Given this list of marker genes FIZ1, ZHX1, SAMD1, AIG1, MICALL1, MORF4L2-AS1, LPXN, VEZF1, METTL27, ABHD17A, XPO1, IMPDH1, ZKSCAN2, CTBP2, SHOX2, PKP2, CTDP1 (NCBI Gene Id 9150), GUK1, GMPR2, PCBP1-AS1, BRPF3, ZDHHC8BP, RHBDD2, FBXO24 (NCBI Gene Id 94779), ZMIZ2, PTPN12, IST1, POLR2J2-UPK3BL1, ASCC1, FXYD5, CMIP, RBM26, TSPOAP1, ZNF524, PTPN18, VEGFA, EOLA2, C6orf89, ELP1, HLA-DMA, DIS3, USP21, MAP3K8, NFATC2, RREB1, ZZZ3 (zinc finger ZZ-type containing 3), VANGL2, CDK13, PUSL1, TRABD, GRIN3B, NCAPH2, SAP25, ENSG00000246090, POLR2J3, CHD4, NOTUM, ASXL1 (NCBI Gene Id 23393), HSDL2, P3H3 (NCBI Gene Id 10536), ZNF787, ENSG00000221040, RHBDF1, TPR, RFX7, PPP1R15B, UBE2E3-DT, ZFAND2B, CERS4, OARD1, E2F3, STX16, BHLHE40, HIVEP1, ZNF217, HDAC7, GPR199P, LINC02965, FAM193A, MXD1 (MAX dimerization protein 1), LDAF1, RCOR1, INPP5D, HSPB9, CYFIP1, HOXB-AS1, LINC01391, USP34, EIF5A, RIMKLB, BBX, ZBTB18, MILR1, CAPN1-AS1, ID1, NFKBIA, KMT2D, ENSG00000277182, SFR1, B4GAT1-DT (B4GAT1 divergent transcript), NDUFB2, FLT3LG, USF2, FKRP, CYB5R1, API5, GLUD1, PIPOX, GSTO1, BMP2K-DT, ZNF442, RBCK1, HEATR6-DT, CLDN4, RNU5A-1, UNKL, TUBB2A, GABARAP, ERP29, POC1B, JUN-DT, UBE2I, YWHAZ, GFOD1-AS1, PCGF2, RPGR, MIR4766, TOP1MT, CRK, ENSG00000260132, GATAD1 (NCBI Gene Id 79636), OBSL1, FOXP1, AMOTL1, CAPZB, FAAP20 (NCBI Gene Id 199990), ZNF623, RASA1, GAB1, TPT1, PAN3-AS1, PPM1D, LINC01623, RNY4, BMI1, EPHB4, KCNJ4, NOVA2, FLII, ATP8A1-DT, HJV, STK11IP, C8orf58, ATXN1L, TRMT12, ZNF559-ZNF177, ARFIP1, PSCA, RPL23A, APBA2, UQCR11, MYCBP2-AS1, BRAF, TMEM256, TMEM256-PLSCR3, NBN, SPRED2, SMG7, SNHG26, NRN1L, TM9SF4, AHDC1, ATXN2L, ZFP91, SMIM10L2A, FBXL19, VCF1, RGS4, HOXB3, GPR180 (NCBI Gene Id 160897), INPPL1, TSPAN31, UTP4, RNF14, HMG20B, CDC25C, GIPR, TSPOAP1-AS1, ZNF664 (zinc finger protein 664), C11orf71, ANKRD13C-DT, ABITRAM, CDK12, ARAP1, USP32, DNAH17-AS1, RNVU1-28, MIR9-1HG, HSP90AB1, YWHABP2, ANAPC13, VPS37B, ZBTB22, MAN1C1, GLA, HMGN2, SH2D6, SPRY2, LAMA5, MAST1, ARHGEF7, MIR193BHG, CYTH1, SBK1, CXXC5, ANXA4, CEBPG, TUBA4A, MAML2, GET1, ZXDC, ATP6V1G2-DDX39B, NFIC, ADGRE5, DLGAP1-AS1, SYCP2, SLC39A7, SCYL1, PGAP6, EIF4G3, ECI2, ZFP36L1 (ZFP36 ring finger protein like 1), HYAL2, HCFC1, METRN, DCAF5, RIC1, HNRNPH3, KRI1, ZER1, ZNF579, GCC2-AS1, MATK (NCBI Gene Id 4145), CCND2-AS1, OLFM2, CNOT8, KLF3-AS1, KCNQ1OT1, ATP1B2, GDF11, LDHA, LINC02252, RGL1, CCDC77, UBE3D, UBAP2L, DBNDD1, SDCCAG8 (SHH signaling and ciliogenesis regulator SDCCAG8), ILRUN, F2RL3, TBXAS1, ASB7, SUPT3H, DVL3, FCHO1, PFN1, PLA2G12A, GFOD1, HMGB1 (high mobility group box 1), PSME4, SMIM29, SSC4D, MRPL36, SDCBP, ALAD, CHCT1, FAM21EP, ANKRD13B, SNORD42B, WDR26, PKNOX2, NIPA1, MIR4487, MTNAP1, CSNK1E, IL6ST, CLCN2, PPP2R1A, DENND1C, N4BP2L2, BCR, DCP1B, PAQR6, SAT2, ANKRD62, ANP32B, SHLD2, NR2F6, GPBP1, TNFAIP8L1, COX17, FTX, APH1A, EXOC3L4, PGM3, MIR3190, SCN1B, SYNCRIP (synaptotagmin binding cytoplasmic RNA interacting protein), BCL2L2, ZBTB14, H4C8, ZEB2, TPT1-AS1, DPP9, SPAG1, MAGEA1, HDAC6, BZW2 (basic leucine zipper and W2 domains 2), CCDC92 (coiled-coil domain containing 92), DNAH2, DTD1, KTN1-AS1, SCRT1, USP34-DT, MEIS3, ZBTB39, SBNO1-AS1, NEXN, MIR1538, PPP1R10, MARCHF2, GFI1B (growth factor independent 1B transcriptional repressor), DNAJC30, PKNOX2-DT, SLC12A9, PCBP2, RPS6KA4, TBC1D8B, CA11, TMEM70, TTC5, EFCAB5, TRIM46, MED13, BRD2, PIAS2, SDF4, MIR378D2HG, SMAD3, YES1, HNRNPLL, SNAI1, TRIB2, DAND5, SEMA4G, POLR1D, FSD1, ADH5, TMED3, RPUSD1, SMPD4BP, MEF2C-AS1, OPLAH, RFLNA, AUP1, EPHA2, TUG1, PNPLA7, RASSF5, STAR, PPP1CC, ATP6V1G2, ZNF410, ZBTB21, TRMT112, PIAS4, YWHAE, BAG2, CHRNA1, CADM1, UBR4, CEP131 (centrosomal protein 131), ENSG00000230226, TXN2, TSC22D1, MTBP, MACIR, CASTOR2 (NCBI Gene Id 730322), APC2, ENSA, PGGHG, PRAME, UCK1, SETD1B (NCBI Gene Id 23067), NAGLU, PLXNB1, TEAD2, PHF1, SLC18B1, PDE4A, LRCH4, GRPEL2-AS1, ADPGK, SUMO2, ABL2, DUSP16, ADD2, TONSL, DCLRE1A, ENSG00000246465, MAX, HDHD5, DSN1, MYO15B, TTC7A, JRK, PFKM, RELA, PPP4R1L, ATP5MC1, GSPT1, SPESP1, ATP8B3, CPT1C, INPP5J, LRRC58, ODR4, VRTN, ATP2B4, MIDN, MEX3B, PPP1R26, ACTR3, TET3 (tet methylcytosine dioxygenase 3), TXN, ABCA7, KLF4, MIR497HG, MFN1, MICU3, POLR2J2, CNTN3 (contactin 3), NOSIP, SNORD101, MCMBP, GRK6, EOLA2-DT, SLC2A1, GSTM4, SGCE, ZNF467, DENND4B, USP38-DT, FGFRL1, TRPS1, KCNJ8, KIF21A, UBR1, SYNGAP1, KDM6B, HNRNPF, SNORD3J, PLAGL1, TMEM35B, GART, RCAN3, AMPD2, AKT2, ENTPD6, TYW3, TPX2, RPS6KA3, FABP5P3, POLR2A, IER2, HHEX, MVB12A, RSF1, NAA50, U2AF2, TFB2M, CITED2, HLX, PRR34, SSNA1, SLC25A6, MIR548AW, CD99P1, SRRM1, HARBI1, CHD1, SCAMP2, ZEB1, ZNF592, SOX5, GBA1LP, SLC1A4, SATB2, LIMS1, INTS6-AS1, ZNF581, ITPR3, TPP1, DDIT3, TMEM116, MIR9-3HG, ZC3H7A, PIK3CA, C3orf38, GRHPR, IFIT1, GAS8, BCL2L2-PABPN1, PCF11 (PCF11 cleavage and polyadenylation factor subunit), ANAPC16, PRMT1, NUMA1, ZNF580, SUSD6, FKBPL, LINC02870, HNRNPA2B1, IDI1, MFSD5, IRF2BP1, KLF6, TM2D1, MRPL13, COIL, LINC01366, VAV1, ZDHHC3, TARBP2, PAXIP1-DT, LACTB2, ZFP62, LENG8, ZNF200, GSTM2, COPZ1, HNRNPH2, LINC02130, CUX1, CALM1, MATN1, CYLD, PITPNM3, SRRM2-AS1, RHBDL1, LIG4, PRR12 (NCBI Gene Id 57479), H3-3A, NME3, ZMIZ1-AS1 (NCBI Gene Id 283050), SATB1, NFKB1, AMD1, PRDM10-DT, POLK, ZNF628, CCDC28A-AS1, RBM10, TLE2, SINHCAF, TSPAN4, UNC13A, KRT8, MIR3613, RNF44, BPTF, BEST1, NUDT12, MATN1-AS1, SLC40A1, STK35, TNRC18, TFEB, FXYD7, AMN1, SYCN, TULP2, BCL9, EIF4E1B, LMNB2, AARS1, SLC16A6, MAPK11, CTSH, TLE5, CDCA4, NUDT18, RPS2P4, ATP8A1, FAM193B-DT, TACC3, KMT2C, INF2, CSNK2B, KLHDC4, GGPS1, EIF4A1, ANTKMT, LZTS2, AP1G1, NEO1, ZC3H4, SIK3, NFAT5, SP1, TNKS1BP1, CACNA2D2, RAB10, SCIN, DIAPH1, CDC26, BCL3, RPL36P10, ARL6IP6, JADE2, DNAJC7, TPTEP1, CYREN, ERFE, CLIC2, RETREG2, SSBP3, DNAJB13, EPC1, DDX19B, AAK1, POLN, STRN3, C4orf36 (NCBI Gene Id 132989, chromosome 4 open reading frame 36), SNORA48, LINC02028, PALM3, ARPC5, HOXB5, CILP, ZBTB12, AGPAT3, TFE3, ROCK2, KDM2B-DT, POLR3K, QKI (QKI, KH domain containing RNA binding), PAFAH1B3, INHA (inhibin subunit alpha), ARAF, ITGA5, ZNF227, EIF2D, AGAP1, MPP1, GTF2I, HTRA2, MIR6089, NKRF, RNF2, KLHL25, H2BC5, BCAR1, RUVBL2, HDHD5-AS1, DMXL1, CGRRF1, ASTN2, FCHSD1, CIRBP (cold inducible RNA binding protein), ARHGAP22, GAD1, HR, TENT4B, LEPR, TMEM259 (transmembrane protein 259), RPS7, ELF2, RAD17, RPTOR, MTCH2, RN7SKP175, ZNF280D, GTF3C2-AS2, COX20, NYAP1, WDR37, SRCIN1 (NCBI Gene Id 80725), RELT, DPP8, UBE2Z, DIXDC1, GLS, STXBP4, KDM3B (lysine demethylase 3B), HS3ST3B1, ZBED6, STAG3, SS18L1, PAXIP1, PAX6, CUL4B, MCCC2, TLK1, TAF9, MMACHC, NEDD8-MDP1, KIFC2, HEXIM2, MGAT4B, DPF1, FAM72A, TMC6, GHDC, PRELID3BP5, WSB2, MAP1A, MTF2, RBM3, HEXD, FARP2, SAE1, VIRMA, GPANK1, ZNF628-DT, MOB3C (MOB kinase activator 3C), CFAP298, PARK7, PURB, ARHGAP23, PPP1CA, LSR, ACTR8, SCML1, SQSTM1, VAT1, CDC42EP1, TRIM32, TMEM187, ZNF783, CAMTA2, SLX4, PANK3, MYL6, BRSK1, CDKL3, TIGD5, WEE1P2, PHACTR2, NATD1, ZKSCAN8, IRF2BP2, CDC16, MME, BCL2L1, ANP32A, FOXP1-DT, ZFP91-CNTF, PTPRS, CNTRL, WDR54, LRCH1, SNORA57, ATP7B, ZNF211, HSP90B1, AMPD3, INO80D-AS1, EOGT, RNVU1-15, EP300, UBTF, PIK3CA-DT, LINC01134, NUCB2, LINC03016, DNAAF10, HSDL2-AS1, RNU6-2, MORF4L2, GTF2IP1, ADSS1, TMED1, CNIH3, AHNAK2, RAE1, CLTC, MPG, CHD7, HSD3B7, WDTC1, PSMA7, RBM39, LAMTOR3, CHRNA7, CNOT4, EFHD2-AS1, DAXX, CASZ1, TGFBR3, DDX11L17, STX16-NPEPL1, TP53INP1, GNB2, BBC3, RASL10B, BRI3, GTF2IP4, CSKMT, MLST8, TAGLN2, ELFN1-AS1, CMTM3, PRRT1, DNAJA1 (NCBI Gene Id 4737), HMX3, XKR9, GRTP1, ZKSCAN5, HMGB1P50, TAF15, RFPL1S, MIR6835, R3HCC1, PPFIA3, SMPD4, TPTEP2, PRPF40A, SNHG25, EFHD2, HSF2, UBXN11, C1orf174, TNRC6A, FAM117B, SPART, IKZF4, PMS2P4 (PMS1 homolog 2, mismatch repair system component pseudogene 4), ST7L, RNVU1-27, SOX18, RPS6KB2, DYNC1LI2-DT, CNPPD1, KMT5B, LURAP1, EPC2, CAMSAP2, ACTR3B, AP2A1, MAGEC1, MIS12, VIRMA-DT, LRRFIP1P1, ZHX1-C8orf76, LTBP4 (latent transforming growth factor beta binding protein 4), CHIC1, PROSER2-AS1, AP3M1, TENT2, WDTC1-DT, JPH3 (NCBI Gene Id 57338), MTA2, KPNB1 (karyopherin subunit beta 1), MPHOSPH9, MTPAP, URAHP, SLCO4A1, SFMBT1, SLC20A1, HAUS8, ENSG00000229227, CCDC183, USP44, SUMO1, ANP32E, XIST, PTPN7, LINC01521, NME4, TRIM25 (NCBI Gene Id 7706), RTL6, SSR1, S100A1, ARAP3, ZNF653, SMG7-AS1 (SMG7 antisense RNA 1), CRYZ, GATA2, LAX1, SMARCA4, HEXIM2-AS1, MAGED2, ANKRD34A, NIBAN2, TTC17, HID1, LRRC4B, PHF23, IDH1, FAM193B, TOP3B, CPSF1, COL1A1, MUC4 (NCBI Gene Id 55804), GTF3C2, SATB2-AS1, CLPX, SLC12A2, ZSCAN31, ZNF710, SH2B3, LINC02916, PLEC, MDM2, FUNDC2, GAB3, TMEM198B, LINC03072, SMIM27, UBA7, NDE1, KAT6B, TSHZ1, AP4S1, OAF, ELAVL3, ATP1B3, PI4KB (phosphatidylinositol 4-kinase beta), LINC01732, HAUS3, BCL9L, DHRSX, EHD1, TAL1, DUSP7, RABGAP1, PHF12, ATP6V1A, PCNX4, RCOR3, SLC7A6, PIKFYVE (NCBI Gene Id 387568), RNF43, KCTD15, STMN1 (NCBI Gene Id 3925), ZBED1, F8, PLCG1-AS1, MUL1, HOXB9, FTL, TSC1, MAGEF1, SNORA56, GNL3L, ZC2HC1C, AKAP9 (NCBI Gene Id 10582), ZNF687, ABTB2, IGLON5, ZNF395 (NCBI Gene Id 55893), DYNC1LI2, IGF2R (insulin like growth factor 2 receptor), LMAN2L, PDGFA, DNALI1, ING1, SNRNP25, TMIE, CARS2, LDAH, TEX14, CREB3L1, MIR4472-2, TMCC2, MMP25-AS1, TGIF1, CGGBP1, LEMD1, MNS1, RARA, LIN28A, JUN, EIF3J, ADK, GPR107, TFDP1, WDR90, MEF2C, FGD6, LGI4, KLK10, CCDC106, NUP153-AS1, EIF4G1, SCARB1, HERC4, SMG1P3, INTS6, VPS11, PDE3B, SYT3, APEH, INHBE, MAP3K12, ZC3H3, TBX21, MAPKAPK3, AKIRIN1, DDX23, RPL7A, PRR5 (NCBI Gene Id 86335), NFIB, ZNF687-AS1, ELOA-AS1, MMP17, SSRP1, NDST1-AS1, NFE2L2, MANSC1 (NCBI Gene Id 54682), ZNF771, MAP1B, BUD23, RNU2-17P, SNX16, CEP164, VPS51, RCN1, VSTM5, USP22, JADE1, LNX2, C19orf38, DNAJB2, IMPA2, NDUFAF2, BRWD3 (bromodomain and WD repeat domain containing 3), LCORL, ZNF346, DNMT1, PCGF1, ELF4, TMEM129 (transmembrane protein 129, E3 ubiquitin ligase), ENSG00000267424, AFF1, KAT2A, ARRDC2 (NCBI Gene Id 27106), KMT2A, PRKD2, SH2B1, BRPF3-AS1, DMXL1-DT, EXOSC7, CCDC163, ITGAV, ATG13, PNRC1-DT, TEX9, WAC, KCNIP2, PDGFA-DT, MYO18B, S100A13, ASH1L, PEG10, RICTOR, RAP2C, ZHX3, RLN3, ARCN1, CD81-AS1, SHKBP1, MGME1, WIZ, SEPTIN2, TOB2P1, UBE2V1, STMN3, METAP1, TBC1D32, ATXN7L3, ESR2, MIR3181, PNISR (PNN interacting serine and arginine rich protein), PCYOX1L, GPR161, EZH2, MIR6821, PTPN4, MIS18A, YLPM1, CTCF-DT, TERC, MLLT6, ADNP, LINC01229, CHTF18, SEPTIN11 (NCBI Gene Id 55752), NSD1, JAG2, ADAM17, CD9, TNK2, ZNF436, FAM83E, C1orf74, DDX55 (DEAD-box helicase 55), ELOC, BCORL1, CDK13-DT, CTPS1, DCTN4, ATP11C, USP38, WDR83OS (NCBI Gene Id 51398), RPL41, HEY1, SRSF1, PNRC1, ABHD6, MIR4285, SHFL, QPCT (NCBI Gene Id 25797), LINC02920, E2F2, CHRNE, POLE3 (DNA polymerase epsilon 3, accessory subunit), SLC12A2-DT, BNIP1, ECI2-DT, RBFOX2 (RNA binding fox-1 homolog 2), TMEM245, UBE2E3, EPM2A, PICK1, LINC02332, ZKSCAN2-DT, UBE2Q1, TRPA1, NBR1, NFATC3, WASL-DT, ANKMY2, ARPC1B, C1RL, REM2, PDXK, B4GAT1, NES, C1orf43, INO80, FOXO4, CCND2, F12, POU2F1, CDK5RAP3, PROCA1, HMG20A, PLEKHA7, LRRC51, GGA2, KIAA0586, DHRS13, ARHGAP5, GYS1, EFCAB14, MBD5, CEP63, DGKZ, LEPROTL1, WAPL-DT, TRMT61A, TTC41P, POLR2L, PHF21A, RBM7, SKIL, CSF3R, EBP, PDP1, EIF4B, EEF1D, PSMD7, PIK3R1, ITPKB, BRD7, WRNIP1, C19orf73, RHOBTB3, MIR1208, CLCNKB, ARID4B, LINC01144, BLVRB, ZNF329, CDK5RAP2 (NCBI Gene Id 55755), GLI1, BTNL12P, HOXC9, DERL2, DENND1B, EIF3J-DT, NAA40, SEMA4C, C9orf43, KDM2B, SNORD104, MAP2K4P1, WDR43, PUM1, ZNF768, LNCPTCTS, FAM78B (family with sequence similarity 78 member B), SBNO1, TMTC4, SKIDA1, LINC00620, MCFD2, PURA, LDOC1, TMEM120B, VEGFB, MMP11 (matrix metallopeptidase 11), H3-3A-DT, MBOAT7, TRAF3, TASOR2, KDM2A, MRPL41, ENTPD3, SDC4, MBD6, GNAI2, ATXN2-AS, SLC8A2, TUBB, NHLRC2, TRMT61A-DT, CACNA1H, HOXB2, CLK4, SLC25A22, FOXJ2, LNC-LBCS, UBE3A, PLXNA3, GTF2IRD2B, TPP2, HOXB6, MAFA, ZNF644, TPGS1, RPRD2, RAB3IL1, STX6, MAGI1 (NCBI Gene Id 9223), MLLT10, GCAT (NCBI Gene Id 23464), NCOA2, STRN4, YWHAG, NEAT1, MIR4729, ZEB1-AS1, RGL2, DLG4, ZDHHC8, HNRNPUL1, SMARCA1, TCF4, CLDN6, ADD3, CAPZA1, TLK2, TMEM216, SRGAP2, ATP5F1A, PRDX4, CROCC (NCBI Gene Id 9696), ARHGAP5-AS1, NLK, GRIK5, KCNN1, COPS7A, MECP2, ATF6B, KDM5B, MZT2A, ACYP2, HDLBP, NFKB2, CRB2, ZNF436-AS1, DHX58, FXN, HMGN1, ANKRD11, DKKL1, KAT6A, SLC25A17, SEC13, TPSP2, CCDC66, S1PR2, PAFAH1B2, LMNA, DPY19L4, PSMB6, EPC1-AS2, XKR6, NOTCH3, CTC1, LMF2, DBP, RBM33-DT, MED13L, RND2, RAB7A, UBL3, ATXN7L2, CCL3-AS1, C11orf98, ACAP3, RCAN1, POLR2E, ZEB2-AS1, RNU6-268P, SAMD12, HDHD3, MIR4492, CRACR2B, MIR4466, VAV2 (vav guanine nucleotide exchange factor 2), SRSF10, LINC01635, HSPB8, SHBG, ADAR, TRIB1, MADD, ORC4, RNVU1-18, ZNF503-AS1 (NCBI Gene Id 253264), PNO1, CHCHD10, SPTBN4, G3BP2, NFYA (NCBI Gene Id 56008), TMEM39A, PATZ1, ATXN2, ACYP1, HSP90AA1, POLR2J, LMO4, ENSG00000187186, BLVRA, MAZ, EED, RPS12, CCDC28A, CEP170, FAM222B, STRIP1, GPR35 (G protein-coupled receptor 35), NFKBIL1, KLC2-AS2, PPP2R2A, NLGN2, IPO8, CARINH, ETF1, ZMAT1, TSPYL1, FKBP8, AMFR, PRKAG1, SEPTIN7P13, ANAPC2, NR3C2, CTDSP1, PPP2R5B, ZFTRAF1, EIF4E, TCP11, BCRP8, RGS12, GPRIN1, DAZAP2, XPO7, KCNH2, MZT2B, LINC01089, ANO7, CERT1, ENO3 (enolase 3), PASD1, MSL1, GALNT16, NR4A1, RAP2C-AS1, MED22, POMT1, PLK1, RBM26-AS1, ACTB, NRIP1, EPC1-AS1, RILP, AGAP2, CCDC86, SGO2 (shugoshin 2), YIF1B, SEC24C, FXR1, ERGIC1, POU6F1, WAC-AS1 (WAC antisense RNA 1 (head to head)), PHC1, KLHL13, RNVU1-22, TRPM4, UBE2B, NDUFA4L2, RAD51C, SSR4, LINC00339, SCARNA2 (NCBI Gene Id 677766), CDC42BPB, UHRF1, SAR1A, PDS5B, DYNLL1, CBX3, HAPSTR2, ISL2, PRKX, TIMM44, THAP6, FAM53C, DNAJC14, CCNB3, DRAM1, DDX54, MARCHF6, WASL (NCBI Gene Id 8976), RAB3A, TIMM9, WDR83, KCTD7, NEDD8, KEAP1, PPP1R12A, MARCHF6-DT, MORF4L1, LINC02798, LBH, JRKL-AS1, VEZT, PPP3R1, GTF2IRD2, GAL3ST1, ZFYVE1, IKBKB-DT, ATP2C1, SRRM2, IFT122, MAFTRR, GRB2, POGZ, PYCR2, CACNA1A, VPS28, PLEKHA6 (NCBI Gene Id 22874), AKT3, HDAC5, PPFIA4, ZBTB4, MRPS2, ADGRE2, PPP1R12A-AS1, FRG1JP, AAMDC, LIG1, TMOD1, ERCC1, ZBTB42, PRPF4, TUBA4B, STMP1, CFAP410, PRKCB, BAZ2B, ZNF318, FAM217B (family with sequence similarity 217 member B), PITHD1, PIERCE1, APTX, SLC25A23, TRIM8, ETV3, CAPN1, HNRNPL, HEATR6, PBX2, HLCS, CYGB, STK25, ILRUN-AS1, LINS1, ZSWIM9, LINC01976, ARNT, RYBP, SAMD11, ZMYM2, TRAF4, PEAK1, RITA1, FSCN1, RBX1, NAA11, TRNP1, PREX1, SRCAP, TAF1 (TATA-box binding protein associated factor 1), MSMP, BMP2K, MARF1, ARHGEF25, KDM5A, KAT2B, ZBTB7A, SNORA50C, HIF1A (NCBI Gene Id 3091), MYCL, IDH3G, IGF2BP2, NFYC, ZYG11B, LMTK3, SUPT20H, MYL6B-AS1, KEL, CHD3, LRFN4, here is a description of the gene set: Genes containing one or more binding sites for (ZNF740) in their promoter regions (TSS -1000,+100 bp) as identified by GTRD version 20.06 ChIP-seq harmonization. species: Homo sapiens Human Gene Set: ZNF740_TARGET_GENES from publication Yevshin I, Sharipov R, Kolmykov S, Kondrakhin Y, Kolpakov F (PMID 30445619)